The following is a description of a gene set: Mouse Gene Set: CUI_MONOCYTE_IL3_RESPONSE_DN from publication Cui A, Huang T, Li S, Ma A, Pérez JL, Sander C, Keskin DB, Wu CJ, Fraenkel E, Hacohen N (PMID 38057668) Genes negatively differentially expressed in cell type: Monocyte upon treatment with cytokine: IL-3 in mouse lymph nodes in vivo. Cytokines mediate cell-cell communication in the immune system and represent important therapeutic targets. A myriad of studies have highlighted their central role in immune function, yet we lack a global view of the cellular responses of each immune cell type to each cytokine. To address this gap, the authors created the Immune Dictionary, a compendium of single-cell transcriptomic profiles of more than 17 immune cell types in response to each of 86 cytokines (>1,400 cytokine-cell type combinations) in mouse lymph nodes in vivo. A cytokine-centric view of the dictionary revealed that most cytokines induce highly cell-type-specific responses. For example, the inflammatory cytokine interleukin-1β induces distinct gene programmes in almost every cell type. A cell-type-centric view of the dictionary identified more than 66 cytokine-driven cellular polarization states across immune cell types, including previously uncharacterized states such as an interleukin-18-induced polyfunctional natural killer cell state. studied in species Mus musculus, and this is the list of marker genes: Smpdl3a, Cybb, Sat1, Klf4, Coro1a, Itm2b, Hspa1a, Glipr1, Npc2, AB124611, Lst1, Serinc3, Camk1d, Fosb, Cd52 (NCBI Gene Id 23833), Fau, Msrb1, Lmo1, Higd2a, Eef2 (eukaryotic translation elongation factor 2), H2ac24, Gpx1, Lsp1, Cdkn2d, Jund, Ypel3, Cox7a2l, Klra2, Lyz2, Hpgd, Metrnl, Apoe, Fos, H2-D1, Klf2, Plac8, Ifitm3, Hacd4, H2-K1, Stat3, Pltp, Ifitm2, Hspa1b, Gngt2, Arhgef18, Cx3cr1